The following is a description of a gene set: Pentose phosphate pathway in senescent cells Human Gene Set: WP_PENTOSE_PHOSPHATE_PATHWAY_IN_SENESCENT_CELLS species: Homo sapiens, and this is the list of marker genes: RPE, DERA, PGLS, RPIA, PRPS1L1, G6PD (glucose-6-phosphate dehydrogenase), TALDO1, TP53